The following is a description of a gene set: part of: NCAM signaling for neurite out-growth The neural cell adhesion molecule, NCAM1 is generally considered as a cell adhesion mediator, but it is also considered to be a signal transducing receptor molecule. NCAM1 is involved in multiple cis- and trans-homophilic interactions. It is also involved in several heterophilic interactions with a broad range of other molecules, thereby modulating diverse biological phenomena including cellular adhesion, migration, proliferation, differentiation, survival and synaptic plasticity. studied in species Homo sapiens Reactome Pathway: NCAM1 interactions, and this is the list of marker genes: AGRN, PRNP, COL5A2, CACNA1D, CACNA1G, PSPN, GDNF, CACNB4, COL4A3, NCAN (neurocan), COL4A1, CACNA1I, COL4A4, COL3A1, COL5A1 (collagen type V alpha 1 chain), COL9A3, COL9A1, ST8SIA2, COL2A1, ARTN, GFRA1, COL6A3, GFRA2, COL4A5, ST8SIA4, CACNB2 (calcium voltage-gated channel auxiliary subunit beta 2), COL6A6, COL5A3, COL6A2, CACNA1C, CACNB1, COL6A5, NRTN, GFRA4, CACNA1S, NCAM1, COL4A2, CACNB3, CACNA1H, COL6A1, CNTN2, COL9A2